The following is a description of a gene set: Subpopulations of human fetal thymocyte and circulating naïve T cells were obtained through FACS sorting, including CD3-CD4+CD8- intrathymic T progenitor cells (ITTP), CD3intCD4+CD8+ \double positive\ thymocytes (DP), CD3highCD4+CD8- \single positive\ thymocytes (SP4), CD3+CD4+CD8-CD45RA+CD62L+ naive T cells from cord blood (CB4+), and CD3+CD4+CD8-CD45RA+CD62L+ naive T cells from adult blood (AB4+). from publication Lee MS, Hanspers K, Barker CS, Korn AP, McCune JM (PMID 15210650) Genes down-regulated in naive CD4 T cells from cord blood versus thymic stromal cells. Human Gene Set: GSE1460_NAIVE_CD4_TCELL_CORD_BLOOD_VS_THYMIC_STROMAL_CELL_DN species: Homo sapiens, and this is the list of marker genes: ENSG00000291006, PSMD10, PLK4, THG1L, IFT46, SLC35A5, RAB9A, ACTR1A, MLH1, DNAJC6, GMPS, TRAM1, GALNT7, RAB20, NCAPG2, ERCC6L, CPQ, RAP1GDS1, ATF3, CTSK, SRF, BTG3, MAP1LC3B, VDAC1, PSMD5, PGGT1B, SPON2, STAM2, HES1, FAM200C, RAD23B, STBD1, CBY1, CHPT1, RPS27L, SLC6A8, MRPL42, GCNT1, UGGT1, DHCR24, RHOQ, MRPL35, TRO, TUBB3, TNFSF13, ZDHHC4, FEZ2 (fasciculation and elongation protein zeta 2), IDH2, RYK, ELOA, NUP155, LSAMP, MAP4, CD59, LRP12, CDCA3, FKTN, GGCT, ATP6V1H, PDLIM2, PLPP1, GMPR2, PDCD5, CRELD2, COPB1, OIP5, SCAMP1, SLC19A2, HBS1L, RHEB, ETNK1, NT5DC2, SRPRB, EIF3J, SMS, HYI, CAND2, GNAI3, ARPC1A, PYGL, PEX7, RIDA, RAD17, DET1, AEBP1, PABPC4, TTC33, DUSP14, CCNA2, BMAL2, HJURP, GPALPP1, RTL8A, RCAN1, DYNC2H1, EMILIN1, TMEM43, RNASEH2A, ATG5, AMIGO2, ARMC9 (NCBI Gene Id 80210), CAMK2N1, ELOC, CRIPT, CALM2, GLB1 (galactosidase beta 1), TRIP13, NFE2L2, WDR45B, UBE2V2, RHOBTB3, MANBA, PLPPR4, P4HB, MT1X, NUDT21, SASH1, ETFA, DPY19L1, SMNDC1, SHROOM2 (shroom family member 2), KIF15, IFRD1, DYNC1I2, RAB1A, SCD, POLR3B, HIGD1A, AGAP1, ZFAND1, XPNPEP1, C10orf88, FGF13, FTH1P5, TGFBR3, MFSD1, DUSP12, PPCS, SIL1, CAMSAP2 (calmodulin regulated spectrin associated protein family member 2), ARHGAP5, ATXN1 (ataxin 1), SOS2, CENPN, TFPI, PGD, MMADHC, RAB4A, APMAP, ZNF282, ABCE1, CRYBG3, SLC25A32, SEC13, FKBP3 (FKBP prolyl isomerase 3), NCAM1, IBTK, PPIA, MCFD2, DHRS7, NGRN, PTEN, CHMP2B, TNFAIP1, POGLUT2, NARS1, AP5M1, CDC7, FAM3C, MINDY3, TM9SF1, CHCHD3, PRNP, DNAJC10, HMGCR, JAG1, EDNRB, RHOA, RHOBTB1, SCFD1, NDUFA1, LPAR4, NAP1L3, LDB2, SGK1, RIT1, SPA17, BRIP1, RNF24, ATP6V0C, TRPS1, SSH1, GSTP1, TUBB6, SLC25A46, RAB5IF, MT2A, NTM, DTWD1